Given this list of marker genes Zfp36l2, Fosb, Btg2, Nr4a1, Stk17b, Ddx5, Jun, Junb, Emb, Ppp1r15a, Dusp1, Fos, here is a description of the gene set: studied in species Mus musculus Cytokines mediate cell-cell communication in the immune system and represent important therapeutic targets. A myriad of studies have highlighted their central role in immune function, yet we lack a global view of the cellular responses of each immune cell type to each cytokine. To address this gap, the authors created the Immune Dictionary, a compendium of single-cell transcriptomic profiles of more than 17 immune cell types in response to each of 86 cytokines (>1,400 cytokine-cell type combinations) in mouse lymph nodes in vivo. A cytokine-centric view of the dictionary revealed that most cytokines induce highly cell-type-specific responses. For example, the inflammatory cytokine interleukin-1β induces distinct gene programmes in almost every cell type. A cell-type-centric view of the dictionary identified more than 66 cytokine-driven cellular polarization states across immune cell types, including previously uncharacterized states such as an interleukin-18-induced polyfunctional natural killer cell state. Genes negatively differentially expressed in cell type: γδ T cell upon treatment with cytokine: IL-27 in mouse lymph nodes in vivo. from publication Cui A, Huang T, Li S, Ma A, Pérez JL, Sander C, Keskin DB, Wu CJ, Fraenkel E, Hacohen N (PMID 38057668) Mouse Gene Set: CUI_T_CELL_GD_IL27_RESPONSE_DN